The following is a description of a gene set: studied in species Mus musculus Polarized hepatocytes expressing hyperactive Ha-Ras adopt an invasive and metastatic phenotype in cooperation with transforming growth factor (TGF)-beta. This dramatic increase in malignancy is displayed by an epithelial to mesenchymal transition (EMT), which mimics the TGF-beta-mediated progression of human hepatocellular carcinomas. In culture, hepatocellular EMT occurs highly synchronously, facilitating the analysis of molecular events underlying the various stages of this process. Here, we show that in response to TGF-beta, phosphorylated Smads rapidly translocated into the nucleus and activated transcription of target genes such as E-cadherin repressors of the Snail superfamily, causing loss of cell adhesion. Within the TGF-beta superfamily of cytokines, TGF-beta1, -beta2 and -beta3 were specific for the induction of hepatocellular EMT. Expression profiling of EMT kinetics revealed 78 up- and 235 downregulated genes, which preferentially modulate metabolic activities, extracellular matrix composition, transcriptional activities and cell survival. Independent of the genetic background, platelet-derived growth factor (PDGF)-A ligand and both PDGF receptor subunits were highly elevated, together with autocrine secretion of bioactive PDGF. Interference with PDGF signalling by employing hepatocytes expressing the dominant-negative PDGF-alpha receptor revealed decreased TGF-beta-induced migration in vitro and efficient suppression of tumour growth in vivo. In conclusion, these results provide evidence for a crucial role of PDGF in TGF-beta-mediated tumour progression of hepatocytes and suggest PDGF as a target for therapeutic intervention in liver cancer. from publication Gotzmann J, Fischer AN, Zojer M, Mikula M, Proell V, Huber H, Jechlinger M, Waerner T, Weith A, Beug H, Mikulits W (PMID 16607286) Human Gene Set: GOTZMANN_EPITHELIAL_TO_MESENCHYMAL_TRANSITION_UP Genes up-regulated in MMH-RT cells (hepatocytes displaying an invasive, metastatic phenotype) during epithelial to mesenchymal transition (EMT)., and this is the list of marker genes: TEAD2, CSF1, ITGB1, ACTA2, COL4A1, RPSA, COL5A2, DCK, COL4A2, OAT, GADD45B, CCL7, PROS1, COL1A1 (NCBI Gene Id 4970), SNAI1, CCN2, PLA2G4A (NCBI Gene Id 5321), MCM3, GLG1, PAFAH1B1, PKP1, NR2F1, ZFX, CENPA, CHEK1, TPP2, TGFB3, INHBA (inhibin subunit beta A), INHBB, BRCA1, PLK4, RBBP6, TIMP3, COL18A1, SMARCD1, FBLN2, FURIN, ODC1, TRAF3, MKI67, PPIC, FN1, CCL2, MAP4, CHRNB1, TIMP1, KIFC1, NCAM1, HMGB1 (high mobility group box 1), TNC, COL3A1, CYP1B1, IL4R, CLU, CTSV, GATA2, PDGFA, SMAD1, JUN, CDH2, ABCB1, MPDZ, EDN1, SERPINE1, IRGM (immunity related GTPase M), CCT6A, IGFBP7, RBL1, TOP1